Given this list of marker genes FLNB, TBCE, HPGD, COL11A1, CSPP1, KIAA0586, TBX15, MEG3, RTL1, CHRNG, DLK1, RNU4ATAC, SETBP1, PCNT, LBR, here is a description of the gene set: Human Gene Set: HP_LONG_CLAVICLES Long clavicles Increased length of the clavicles. species: Homo sapiens